The following is a description of a gene set: Inflammation in any serous cavity. species: Homo sapiens Human Gene Set: HP_SEROSITIS Serositis, and this is the list of marker genes: CTLA4, KIAA0319L, CRB2, PTPRO, IL23R, ACTN4, MECP2, DNASE1, UBE2L3, HBA1, IFNGR1, NUP93, PMM2, CR2, MAF, ANLN, GAPVD1, PRG4, BLK, ARHGDIA, IRF4, NUP37, PLCE1, NOD2, NF1 (neurofibromin 1), PTPN22, COL4A3, TRPC6, HLA-DPA1, ETS1 (ETS proto-oncogene 1, transcription factor), C4A, IGHG1, PAX2, TLR7, IRF5, ELANE, LACC1, ERAP1, BANK1, MAGI2, HLA-DRB1, MEFV, KLRC4, MYO1E, IL6, C4B, TNFSF4, FAS, NPHS1, BRCA1, HBA2, DOCK11, MYH11, FOCAD, FCGR2A, MVK, TNFRSF1A, NUP160, SPP1, TNIP1, IL10, NCF2, TLR4, NUP85 (nucleoporin 85), CCR1, P4HA2, HLA-B, NPHS2, EMP2, COQ8B, APOL1, CDC45, CALR, HLA-DPB1, JAZF1, PRTN3, INF2, MIF, TBC1D8B, NUP133, ANKFY1, IL12A, PXK, CFB, STAT4, DAAM2, LCK, IL12A-AS1, FCGR3B, ARHGAP24, TNFAIP3, JAK2, ITGAM, WT1, F5, UBAC2, RNU7-1, IRAK1, CD2AP, PDCD1, NUP205 (NCBI Gene Id 23165), NUP107, FCGR2B, TREX1